Given this list of marker genes POGLUT1, SCNN1B, ENG, HLA-DPB1, SCNN1G, SCNN1A, DNAH11, CFTR, here is a description of the gene set: Reduced FEV1/FVC ratio Abnormally low FEV1/FVC (FEV1 - forced expiratory volume in 1 second; FVC forced vital capacity). Human Gene Set: HP_REDUCED_FEV1_FVC_RATIO species: Homo sapiens